Given this list of marker genes Adi1 (NCBI Gene Id 217448), Glul, Slc11a2, Cdo1 (NCBI Gene Id 76278), Car3, Gstm1, P2rx2, Fhit, here is a description of the gene set: species: Mus musculus Binding to a nickel (Ni) cation. Mouse Gene Set: GOMF_NICKEL_CATION_BINDING